The following is a description of a gene set: Any process that activates or increases the frequency, rate or extent of DNA-directed DNA polymerase activity. Human Gene Set: GOBP_POSITIVE_REGULATION_OF_DNA_DIRECTED_DNA_POLYMERASE_ACTIVITY species: Homo sapiens, and this is the list of marker genes: RFC2, RFC5, RFC4, DSCC1, RFC3, POLG2, CHTF18, PCNA (proliferating cell nuclear antigen), CHTF8